The following is a description of a gene set: Genes containing one or more binding sites for (ZNF544) in their promoter regions (TSS -1000,+100 bp) as identified by GTRD version 20.06 ChIP-seq harmonization. species: Homo sapiens Human Gene Set: ZNF544_TARGET_GENES from publication Yevshin I, Sharipov R, Kolmykov S, Kondrakhin Y, Kolpakov F (PMID 30445619), and this is the list of marker genes: MIRLET7BHG, FBXO44, TOM1, LINC00330, BCL7C